The following is a description of a gene set: TSH-DUOX2-TG signaling pathway. Pathway ID: N00793. Pathway type: Reference. Pathway class: nt06322 TRH-TSH-TH signaling. Pathway Definition from KEGG: TSHB -> TSHR -> GNAQ -> PLCB -> (Ca2+,DAG) -> PKC -> DUOX2 -> H2O2 -> TG studied in species Homo sapiens Human Gene Set: KEGG_MEDICUS_REFERENCE_TSH_DUOX2_TG_SIGNALING_PATHWAY, and this is the list of marker genes: PRKCA, PLCB3, TG, PLCB2 (phospholipase C beta 2), PRKCB, DUOX2, TSHB, GNAQ, PRKCG, PLCB4, TSHR, PLCB1